The following is a description of a gene set: The eukaryotic cell cycle in which a cell is duplicated without changing ploidy, occurring in the embryo. species: Mus musculus Mouse Gene Set: GOBP_MITOTIC_CELL_CYCLE_EMBRYONIC, and this is the list of marker genes: Ctnnb1, Pdgfb, Fzd3, E4f1, Hes1